The following is a description of a gene set: An abnormally increased tendency towards muscle fatigue induced by physical exercise. Exercise-induced muscle fatigue species: Homo sapiens Human Gene Set: HP_EXERCISE_INDUCED_MUSCLE_FATIGUE, and this is the list of marker genes: SCN4A, KCNJ18, AMPD1 (NCBI Gene Id 270), CACNA1S, TRAPPC11 (NCBI Gene Id 60684), AMPD3, GABRA3, DBH, PFKM, SLC16A1, PGK1, KCNE3 (NCBI Gene Id 10008)